Given this list of marker genes SCD, SLC6A12, LYL1, RGS2, CHEK1, H2AC4 (H2A clustered histone 4), HSPA4L, APOBEC1, MXI1, MBP, FEN1, SLBP, APEX1, ORC5, FOS, GTF2I, ZMAT3 (zinc finger matrin-type 3), LMO4, CCNF, ITGA4, H1-0, MKI67, AURKA, ST8SIA4, ZFP36L1, HELLS, NUMB, RASSF5, ABCG1, ACADM, COL11A2, here is a description of the gene set: Human Gene Set: NEMETH_INFLAMMATORY_RESPONSE_LPS_DN species: Mus musculus Adenosine is released into the extracellular space from nerve terminals and cells subjected to ischemic stress. This nucleoside modulates a plethora of cellular functions via occupancy of specific receptors. Adenosine is also an important endogenous regulator of macrophage function, because it suppresses the production of a number of proinflammatory cytokines by these cells. However, the mechanisms of this anti-inflammatory effect have not been well characterized. We hypothesized that adenosine may exert some of its anti-inflammatory effects by decreasing activation of the transcription factor nuclear factor-kappaB (NF-kappaB), because gene expression of most of the proinflammatory cytokines inhibited by adenosine is dependent on NF-kappaB activation. Using bacterial lipopolysaccharide (LPS)-stimulated RAW 264.7 macrophages, we found that adenosine as well as adenosine receptor agonists decreased the production of tumor necrosis factor (TNF)-alpha, a typical NF-kappaB-regulated cytokine. This effect of adenosine was not due to an action on the process of TNF-alpha release, because adenosine suppressed also the intracellular levels of TNF-alpha. However, cDNA microarray analysis revealed that mRNA levels of neither TNF-alpha nor other cytokines were altered by adenosine in either LPS-activated or quiescent macrophages. In addition, although LPS induced expression of a number of other, noncytokine genes, including the adenosine A2b receptor, adenosine did not affect the expression of these genes. Furthermore, adenosine as well as adenosine receptor agonists failed to decrease LPS-induced NF-kappaB DNA binding, NF-kappaB promoter activity, p65 nuclear translocation, and inhibitory kappaB degradation. Together, our results suggest that the anti-inflammatory effects of adenosine are independent of NF-kappaB. Genes down-regulated in RAW 264.7 cells (macrophage) 3 hr after stimulation with bacterial lipopolysaccharide (LPS). from publication Németh ZH, Leibovich SJ, Deitch EA, Vizi ES, Szabó C, Hasko G (PMID 12766259)